The following is a description of a gene set: Cytokines mediate cell-cell communication in the immune system and represent important therapeutic targets. A myriad of studies have highlighted their central role in immune function, yet we lack a global view of the cellular responses of each immune cell type to each cytokine. To address this gap, the authors created the Immune Dictionary, a compendium of single-cell transcriptomic profiles of more than 17 immune cell types in response to each of 86 cytokines (>1,400 cytokine-cell type combinations) in mouse lymph nodes in vivo. A cytokine-centric view of the dictionary revealed that most cytokines induce highly cell-type-specific responses. For example, the inflammatory cytokine interleukin-1β induces distinct gene programmes in almost every cell type. A cell-type-centric view of the dictionary identified more than 66 cytokine-driven cellular polarization states across immune cell types, including previously uncharacterized states such as an interleukin-18-induced polyfunctional natural killer cell state. Mouse Gene Set: CUI_NK_CELL_IFNB_RESPONSE_DN Genes negatively differentially expressed in cell type: NK cell upon treatment with cytokine: IFN-β in mouse lymph nodes in vivo. species: Mus musculus from publication Cui A, Huang T, Li S, Ma A, Pérez JL, Sander C, Keskin DB, Wu CJ, Fraenkel E, Hacohen N (PMID 38057668), and this is the list of marker genes: Klrd1, Pdcd4, Anxa1, Prkacb, Dok2, Cd44, Fth1, Limd1, H2az2, Rasal3, Dnajc15, Fau, Arhgap9, Stk10, Cox7a2l, Cd9, Rasgrp2, Dapk2, Fos, Selplg, Apbb1ip, Add3, Rhob, Cyb5a, Sorl1, Myh9, Ccr2, Il7r, Ptpn18, Polr2i, Tle5, Higd2a, Thy1 (NCBI Gene Id 21838), Crip1 (NCBI Gene Id 12925), Ndufa6, H2az1, Supt4a, S100a10, St3gal6, Ccl5, Rp9, Pdgfb (NCBI Gene Id 18591), Dgkz, Jakmip1, Acaa1a, Ahnak, Lpin1, Rasa3, Mapre2, Fcgr3, Txnip, Cyba, Tspan32, Ucp2, Ltb, Acyp1, Dap, Arhgap45, Zyx, Ccdc88c, Vim, S100a6 (S100 calcium binding protein A6 (calcyclin)), Tcf7, Sh3bgrl3, Klrb1c, Mknk2, Trappc8, Cxxc5, Rack1, Ctsd (cathepsin D), Ripor2 (RHO family interacting cell polarization regulator 2), Tsc22d3, Calm2, Ptprcap, Gnai2, Adgre5, Lasp1, Ifitm10, Kif21b (NCBI Gene Id 320287), Myo1f, Cdkn1b, Ddx17, Adcy7, Efhd2, Gpx4, Cbl, Jak1, Ssbp3, Arhgef18, Scd2 (NCBI Gene Id 226146), Samd3, Ctla2a, Atp1b1, Hmgb1, Sptssa, Eef2, Zbtb38, Arl4d, Mxd4, Ets1, Ifngr1, Ppp1r9b, Uqcrh, Klf2, Kcnab2, Sipa1, Ube2h, Stk38, Nptn, Prex1, Gas7, Pear1, Zmiz1, Ostf1, Rap2b, Ift20, Eif3f, Klf6, Itgal, Klf13 (NCBI Gene Id 80528), S1pr4, Eef1a1, Plec, Rnf130, Uba52, Tyrobp, Ypel3, Neurl3, Cd7, Cxcr3, Pnrc1, Laptm5, Arhgdib, Itgb1, Ggct, Limd2, Tbc1d10c, Hvcn1, Zfp36l2, Qrfp, Pbxip1, Pglyrp1, Emp3, Tecpr1, Traf3ip3, Eef1d, Cited2, Cdk2ap2, Lsp1, Cxcr4, Srpk2, Il18r1, Tnik, Gpi1, Klf3, Entrep3, Acaa2, Rabac1, Pik3r5, Lamtor4, Tm6sf1, Scamp3, Hmgb2, Spn, Btg2, Fosb, Septin1, Pycard, Sytl2, Lamtor2, Prkcb, Bin1, Bnip3l (BCL2/adenovirus E1B interacting protein 3-like), Dusp1, Klrb1a